Given this list of marker genes Ufl1, Optn, Abcb10, Akt1, Cdk5rap3, Erlec1, Ubr5, Ptpn1, Ddit3, Casp12, Agr2, Yod1, Nfe2l2, Amfr, Pmp22 (NCBI Gene Id 18858), Herpud2, Ero1a, Atxn3, Nck2, Atf6, Pacrg, Rnf126, Eif2ak4, Bag3, Atf4, Edem2, Ubr4, Os9, Bak1, Bok, Selenos, Serp1, Akt3, Akirin2, Tmtc4, Dnajb12, Vcp, Ufd1, Ern1, Ifng, Atf6b, Derl3, Ppp1r15a, Pigbos1, Crebrf, Hspb8, Umod, Tbl2 (NCBI Gene Id 97200), Parp16, Tmed2, Creb3, Dnajc18, Akt2 (thymoma viral proto-oncogene 2), Ube2w, Parp8, Tmbim6 (NCBI Gene Id 68309), Ddrgk1, Stc2, Hdac6, Dnajb9, Manf, Derl2 (NCBI Gene Id 93680), Sdf2l1, Ermp1, Ficd, Tmem33, Tmbim4, Igtp (interferon gamma induced GTPase), Bfar, Hspd1, Eif2ak2 (NCBI Gene Id 76759), Eif2ak3, Hsf1, Serp2, Eif2s1, Wfs1 (wolframin ER transmembrane glycoprotein), Daxx, Bax, Atad3a, Tm7sf3, Cops5, Qrich1, Pik3r1, Rhbdd1, Parp6, Dnajc3, Ccnd1, Cav1, Creb3l1, Hspa5, Rpap2, Eif2a, Ptpn2, Vapb, Herpud1, Atf3, Ern2, Abca7, Dnajc10, Nck1, Cul3, Klhl15, Xbp1, Asb11, Pdia6, Edem3, Stub1, Derl1, Bhlha15, Dnajb14, here is a description of the gene set: Any process that results in a change in state or activity of a cell (in terms of movement, secretion, enzyme production, gene expression, etc.) as a result of a protein that is not folded in its correct three-dimensional structure. Mouse Gene Set: GOBP_CELLULAR_RESPONSE_TO_TOPOLOGICALLY_INCORRECT_PROTEIN studied in species Mus musculus